Given this list of marker genes S100a4, Ifi27, B2m, Nr4a2, Rpl38, Gimap7, Lsm5, Aldob, Fxyd2, Cst3, Nkg7 (NCBI Gene Id 72310), Vamp8, Junb, AW112010, Atp5me, Tmem176b, Rgs1 (regulator of G-protein signaling 1), Tnfaip3, Psmb8, S100a11, Cxcr6, Lag3, Ndrg1, Cd28, Gpr183, Fos, Camk2n1, Rnf19b, Slc34a1, Trps1, Fosb, Txn1, Dbi, Cd69 (NCBI Gene Id 76049), Id2, Ifi203, Isg15, Fgl2, Casp8, Gpx4, Igfbp7 (NCBI Gene Id 29817), Spp1, Gpx3, Stmp1, Runx3, Sec61g, Bhlhe40, S100a6, Rpa2, Rida, Zbp1 (NCBI Gene Id 80562), Jund, Klf6, Serpina3g, Hectd1, Fasl, S100a9, Ccl5, Dusp1, Pdcd1, S100a10, here is a description of the gene set: studied in species Mus musculus from publication Tabula Muris Consortium (PMID 32669714) Mouse Gene Set: TABULA_MURIS_SENIS_KIDNEY_T_CELL_AGEING